Given this list of marker genes AKAP4, GCNT2, HCG4, LCAT, GLRB, BRDT, ZNF154, COX10, STARD13, MAP3K14, IL9, PDCL, ZNF264, SLC2A4, ADGRB3, AVPR1A, MLLT3, DOC2A, TPH1, ATRNL1, MATN4, GABRA6, RPGRIP1, CUL3, SPAM1, UGT2B4, PTGDR2, SOX12, NACAD, IL18RAP, OPHN1, SEC14L2, CST5, FSTL4, SLC16A2, RBM17, FRK, VPS41, SYT11, RPGRIP1L, MYH7, C1orf21, GPR176, ART3, SSX2IP, NMBR, KRT37 (NCBI Gene Id 8688), AKR1D1, PRM2, TCF15, KCNA3, HDAC9, CBLIF, P2RY6, MTRF1L, NLE1, MPHOSPH8 (NCBI Gene Id 54737), DCAF4, HIPK2, BAAT, VIPR2, PRORP, ATG4B, DMP1, TNNI2, RFX1, C9, SCN2A, CCL19, ASTN1, LRRTM2, MYBPH, PHKG2 (NCBI Gene Id 5261), RFPL1S, EPHA7, GRM7, ANGPTL7, TEKT2, HOXD9, BTC, ARK2N, CRYBB3, OPN1SW, TNFSF11, SNUPN, KCNH1, PSMD4P1, CHRNA3, SPAG8, DOHH, AP4E1, SLCO2A1, ADAM7, ELF5, NPY5R, GK2, CRP, FAM13C, DCC, BMPER, CD3G, BHMT, ZFY, ODF2, GRM8, AVP, HSD17B2, ZNF239, CYP1A2, SAA4 (NCBI Gene Id 6291), RASGRF1, MINAR1, DZIP1, EIF2B1, GPR4, XPNPEP2 (X-prolyl aminopeptidase 2), ZNF208, TRIM9, PDE6C, SOX3, TRPC3, FOXN2, TMEM8B, WNT1, SLITRK2, NEU3, TCF21, LCT, SERPINC1, TNNT2, IFNA4, KIF1A, IFT88, here is a description of the gene set: Human Gene Set: MORF_LCAT Neighborhood of LCAT studied in species Homo sapiens Neighborhood of LCAT lecithin-cholesterol acyltransferase in the MORF expression compendium